The following is a description of a gene set: studied in species Homo sapiens Human Gene Set: GOBP_SMOOTH_MUSCLE_CELL_CHEMOTAXIS The directed movement of a smooth muscle cell in response to an external stimulus., and this is the list of marker genes: PARVA, CORO1B, AIF1, PDGFRB, LPAR1, SLIT2, GSTP1, MIR34A, MDK, PDGFD